The following is a description of a gene set: Gene expression profile studies have identified an interferon signature in whole blood or mononuclear cell samples from patients with systemic lupus erythematosus. This study was designed to determine whether specific lymphocyte and myeloid subsets freshly isolated from the blood of systemic lupus erythematosus patients demonstrated unique gene expression profiles compared to subsets isolated from healthy controls. from publication Hutcheson J, Scatizzi JC, Siddiqui AM, Haines GK 3rd, Wu T, Li QZ, Davis LS, Mohan C, Perlman H (PMID 18275831) Genes down-regulated in comparison of healthy CD4 T cells versus systemic lupus erythematosus CD4 T cells. Human Gene Set: GSE10325_CD4_TCELL_VS_LUPUS_CD4_TCELL_DN species: Homo sapiens, and this is the list of marker genes: LAMP2, USP46, RBCK1, USP18 (ubiquitin specific peptidase 18), CASP7, MT1H, LGALS3BP, CENPI, PPIF, PIK3R3, MT1F, SOCS1, FHL2, NMI, PLSCR1, ZNF334, CASP1, ISG15 (NCBI Gene Id 9636), IFI35, PTTG1, B3GNT2, SNRPG, CREM, RAB11FIP1, IFI44L, PTTG3P, FAS, GJA1, FRZB, PRPS2, IFIT1, CEACAM1, MMD, MT1HL1, HERC6, DUSP4, H2BC12, MT1X, SNAPC3, ATP6V1A, CDC5L, YARS1, MX1 (MX dynamin like GTPase 1), GADD45A, IFIT5, CEP97, KPNA3, BRINP3, PSME1, PTH2R, ME2, TRAFD1, IFI27, MT2A, MAP3K7CL, HNRNPD, SEMA3G, BMP8B, HDAC9, PMCH, ARG2, IRS1, HTN3 (histatin 3), PSME2, STAMBPL1, APOL1, TOX, LAG3, SAMD9, C1orf21, FAR2, SYT11, PCYT1A, TBK1, ARHGEF3, IFITM1, VRK2, LIPC, IRF7, HERC5, TULP4, FBXO22, TMEM100, DHX58, PARP12, RASGRP3, PTPN2, EIF5A2, OAS2, CLUAP1 (clusterin associated protein 1), EIF2AK2, SOBP, ISG20, PSMA6, ANXA10, IFNG, MYO7A, LAMA2, VANGL1, UBB, MX2 (MX dynamin like GTPase 2), KIF18B, SPO11, OAS1, PHF11 (PHD finger protein 11), FABP5, AIM2, MYD88, GCH1, ATP5MF, DDX60, TAPBP (TAP binding protein), MT1E, HLA-DRB6, UAP1L1, OAS3, CDCA3, SAT1, PTPN22, LAP3 (leucine aminopeptidase 3), ZCCHC2, KIF4A, CSTPP1, RPGRIP1L, KLF10, GSE1, YBX3, MYL6B, RGS1, ICA1, CD200, FCGR3B, TLR5, TNIP2, IGKC, GBP1, TNFSF13, LRP8, BCL2L14, PIAS2, CCR1, WARS1 (NCBI Gene Id 7453), RNASE2, IL7, PMAIP1, CDY1, ADGRV1, RTP4, UBE2L6, DDC, SELP, TRIM21, SP110, HERC2P3, ADGRG6, ARK2N, REC8, WSB2, RSAD2, STAT1, COPS4, TFEC (NCBI Gene Id 22797), FANCA, SLC50A1, PLA2G7, IL12RB2, CENPE, HNRNPA3P1, PFKP, TMSB10, HLA-B, TLR3, SP100, KIAA0513, SPATS2L (NCBI Gene Id 26010), TFDP1, IFI6, IRF4, TRIM22, UBE2Q1, CYP2J2, CXCL13, TAP1, PSMB9, LAMP3, OASL, IFI30, IFI16 (interferon gamma inducible protein 16), HLA-DQA1, IFIH1, XAF1, IFI44, RALA, ARID5B (AT-rich interaction domain 5B, NCBI Gene Id 84159), MRPL42, CAPZA1, UBC, IFIT3, CAPN2